Given this list of marker genes CUL7 (cullin 7), PKDCC, SLC26A2, SNAP25, NEB, CCDC47 (NCBI Gene Id 57003), CFL2, LMX1B, MAD2L2, COLEC10, NGLY1, GLRB, MAP1B, RREB1, SNRPB, DLL1, FBLN5, USP9X, STAG2, LYSET, SLC12A2, COL2A1, MAP3K7, STX1A, FANCG, ATP6V1A, MACF1, TONSL, MASP1, TFE3, DSTYK, HACD1, KMT2D (lysine methyltransferase 2D), EIF4H, B3GALT6, DNAJC30, FLNA, ADAMTSL2, FANCM, COL1A1, MYH3, PORCN, POMT1, EIF2AK3 (NCBI Gene Id 9451, eukaryotic translation initiation factor 2 alpha kinase 3), EXOSC3, YWHAE, FLNB, GLRA1, AARS1, AHDC1, CLCN3, NAA10, GP1BB, ZIC3, GPC3, ZNF469, UBE2T, SEC24C, SLC6A9, TBX1, SLC2A10, PYCR1 (NCBI Gene Id 5831), LONP1 (NCBI Gene Id 9361), IFT56 (NCBI Gene Id 79989), SYT2, MAP3K20, ERGIC1, WNT7A, STXBP1, GLI2, BUD23, ARVCF, SF3B4, GTF2IRD2, SLC18A3, CSGALNACT1, FANCA, ATP6V1E1, CHRM3, SOX9, COL27A1, NEDD4L, BMP4, SHROOM4, YY1, MBTPS2, ATP6V0A2, WNK3, PIGL, NOTCH2, HIRA, PAFAH1B1, COL12A1, VAMP1, GDF5, TGIF1, KDM6A, NSD2, NCF1, FZD2, ITGA7, KANSL1, CLIP2, GPHN, CD96, GAS1, FLI1, GJA1, TRIM8, MKKS, FANCB (FA complementation group B), TOR1A, ATP7A, DVL1 (NCBI Gene Id 348497), HACE1, COLEC11, EYA1, MCTP2, FGFR1, LRP4, EBP, ZC4H2, COL6A3, DISP1, CHRNG, SLC35B2, KIF22, ARNT2, STIL, DHCR7, CTBP1, BICD2, AGRN, IL6ST, HOXA11, PRKACB, HSPG2, FANCD2, UBE3B, BRD4, CRIPTO, TPM2, BPNT2, GMPPB, TBX15, METTL27, LIMK1, MAB21L2 (NCBI Gene Id 10586), COL6A2, OBSL1, FHL1, SPARC, COL13A1, TNNT3, GPC4, AFF3, GORAB, FANCF, UFD1, FANCC, RAD51, TAF6, TBCD, PUF60, ROR2, ECEL1, B3GAT3, COL5A2, SCYL2 (SCY1 like pseudokinase 2), RBM8A, BRIP1, UBE2A, COMT, CHST11, SCARF2, VAC14, GTF2I, ALDH18A1, SLC10A7, CREBBP, COX8A, GNPTAB, RYR3, PYCR2, DNAJC21, EXOC6B, EFEMP2, TBL2, PIK3CA, NSDHL (NAD(P) dependent steroid dehydrogenase-like), LMOD3 (leiomodin 3), EBF3, ERCC4, TMEM270, ATAD1, ERI1, EP300, SMO, HNRNPH1, EIF4A3, FGF8, DPYSL5, SHH, BAZ1B, ALG9, HPRT1, SMOC1, POMT2, FKRP, CHAT, BRCA1, FOXH1, MYL2, SIL1, SIX3 (NCBI Gene Id 6496), FBLN1, MYO9A, FANCE, GSC, FUT8, RECQL4, FIG4, NKX3-2, ACTA1 (actin alpha 1, skeletal muscle), UBA2, TMTC3, PPP2R5D, WNT5A, CANT1, COL25A1, COL1A2, ARF1, CCDC8, LMNA, RYR1, TBX4, XYLT1, FANCL, IFIH1, DHODH, SYNE1, HDAC4, KAT6B, RUNX2, SLC5A7, PIEZO2, ELN, OCRL, NFIX, SMC1A, ERCC1, GEMIN4, BRCA2, CHST3, ABCC9, NODAL, OSGEP, IARS2, LRP1, PHLDB1, ERMARD (NCBI Gene Id 55780), COL6A1, XRCC2, ATR, ZMPSTE24, AEBP1, C12orf57, PLCH1, TELO2, THRA, COL5A1 (collagen type V alpha 1 chain), CLTCL1, FKBP6, SLX4, TPM3, MYH8, FANCI, SELENON, SEC31A, IPO8, FBN2, FGFRL1, CDON, APC, SLC25A1, POLR3B, CPLX1, LTBP1, RAD21, KLHL41, VPS37D, AKT1, RFC2, GLI3, COL3A1, JMJD1C, NIPBL, CEP85L, HK1, PTCH1, ARFGEF2, SMC3, PLOD1, SLC6A5, DVL3, GTF2IRD1, ZIC2, SIX1, PALB2, HDAC8, SLC35A3, ADAMTS2, RFWD3, PTRH2, RAD51C, RNU4ATAC, LETM1, LARGE1, here is a description of the gene set: Displacement or malalignment of one or more joints in the lower extremity (leg). Human Gene Set: HP_LOWER_EXTREMITY_JOINT_DISLOCATION Lower extremity joint dislocation studied in species Homo sapiens